The following is a description of a gene set: part of: TNFR2 non-canonical NF-kB pathway Reactome Pathway: TNF receptor superfamily (TNFSF) members mediating non-canonical NF-kB pathway Activation of NF-kB is fundamental to signal transduction by members of the TNFRSF. Expression of NF-kB target genes is essential for mounting innate immune responses to infectious microorganisms but is also important for the proper development and cellular compartmentalization of secondary lymphoid organs necessary to orchestrate an adaptive immune response. <br>NF-kB transcription factor family is activated by two distinct pathways: the canonical pathway involving NF-kB1 and the non-canonical pathway involving NF-kB2. Unlike NF-kB1 signalling, which can be activated by a wide variety of receptors, the NF-kB2 pathway is typically activated by a subset of receptor and ligand pairs belonging to the tumor necrosis factor receptor (TNF) super family (TNFRSF) members. These members include TNFR2, B cell activating factor of the TNF family receptor (BAFFR also known as TNFRSF13C), receptor activator for nuclear factor kB (RANK also known as TNFRSF11A), CD27 and Fibroblast growth factor-inducible immediate-early response protein 14 (FN14 also known as TNFRSF12A) etc. These receptors each mediate specific biological roles of the non-canonical NF-kB. These non-canonical NF-kB-stimulating receptors have one thing in common and is the presence of a TRAF-binding motif, which recruits different TNF receptor-associated factor (TRAF) members, particularly TRAF2 and TRAF3, to the receptor complex during ligand ligation. Receptor recruitment of these TRAF members leads to their degradation which is a critical step leading to the activation of NIK and induction of p100 processing. species: Homo sapiens, and this is the list of marker genes: MAP3K14, LTB, TNFRSF11A, CD40, BIRC2, TNFSF12, CD40LG, TRAF3, TNFRSF13C, TNFSF13B, LTA, LTBR, TNFRSF12A, TNFSF14, BIRC3, TRAF2, TNFSF11